The following is a description of a gene set: Pathway Definition from KEGG: Vpr -> WEE1 -| (CCNB+CDK1) HIV Vpr to WEE1-cell cycle G2M. Pathway ID: N00460. Pathway type: Pathogen. Pathway class: nt06161 Human immunodeficiency virus 1 (HIV-1). studied in species Homo sapiens Human Gene Set: KEGG_MEDICUS_PATHOGEN_HIV_VPR_TO_WEE1_CELL_CYCLE_G2M, and this is the list of marker genes: CDK1 (NCBI Gene Id 983), CCNB3, CCNB1, CCNB2, WEE1